Given this list of marker genes AHR, CAND2, CAND1, YEATS2, DR1 (down-regulator of transcription 1), RUVBL2, NR3C1, BTAF1, TAF12, BRF2, HHEX, TAF13, GTF2B, RUVBL1, ESR1, TAF1, TAF1L, NR3C2, TAF1B (NCBI Gene Id 9014), GTF2A1, PSMC5, GTF2A2, THRA, DRAP1, BRF1, TAF11, here is a description of the gene set: Human Gene Set: GOMF_TBP_CLASS_PROTEIN_BINDING studied in species Homo sapiens Binding to a member of the class of TATA-binding proteins (TBP), including any of the TBP-related factors (TRFs).